The following is a description of a gene set: from publication Khetchoumian K, Teletin M, Tisserand J, Mark M, Herquel B, Ignat M, Zucman-Rossi J, Cammas F, Lerouge T, Thibault C, Metzger D, Chambon P, Losson R (PMID 18026104) Hepatocellular carcinoma (HCC) is a major cause of death worldwide. Here, we provide evidence that the ligand-dependent nuclear receptor co-regulator Trim24 (also known as Tif1alpha) functions in mice as a liver-specific tumor suppressor. In Trim24-null mice, hepatocytes fail to execute proper cell cycle withdrawal during the neonatal-to-adult transition and continue to cycle in adult livers, becoming prone to a continuum of cellular alterations that progress toward metastatic HCC. Using pharmacological approaches, we show that inhibition of retinoic acid signaling markedly reduces hepatocyte proliferation in Trim24-/- mice. We further show that deletion of a single retinoic acid receptor alpha (Rara) allele in a Trim24-null background suppresses HCC development and restores wild-type expression of retinoic acid-responsive genes in the liver, thus demonstrating that in this genetic background Rara expresses an oncogenic activity correlating with a dysregulation of the retinoic acid signaling pathway. Our results not only provide genetic evidence that Trim24 and Rara co-regulate hepatocarcinogenesis in an antagonistic manner but also suggest that aberrant activation of Rara is deleterious to liver homeostasis. species: Mus musculus Mouse Gene Set: KHETCHOUMIAN_TRIM24_TARGETS_DN Retinoic acid-responsive genes down-regulated in hepatocellular carcinoma (HCC) samples of TRIM24 knockout mice., and this is the list of marker genes: Aldh1a1, Cyp7a1, Prlr, Slc10a1, Cyp26a1, Ar, Fgf1, Thrsp (thyroid hormone responsive)